The following is a description of a gene set: studied in species Homo sapiens Human Gene Set: ZNF510_TARGET_GENES from publication Yevshin I, Sharipov R, Kolmykov S, Kondrakhin Y, Kolpakov F (PMID 30445619) Genes containing one or more binding sites for (ZNF510) in their promoter regions (TSS -1000,+100 bp) as identified by GTRD version 20.06 ChIP-seq harmonization., and this is the list of marker genes: SNHG30, ABCC12, FES, DNAJC6, TTC1, MED21, IFI44L, TTC28-AS1, ZNF607, MTFMT, CCPG1, HAPLN2 (hyaluronan and proteoglycan link protein 2), RANBP3L, ALDOA, RND1, GIT2, LRRC8C, ADAMTS9, ADA, PAXBP1, KAT8, RPL23AP67, EXOSC2, WNT8A, GPR180, FEM1C, NCKAP1L, LRRC8C-DT, HEBP2, NOL6, CWC25, HMGN3, ANGPTL6, PIGB, NLE1, RNF169, EVA1C, EPCIP-AS1, COG6, MTO1, ANAPC5